The following is a description of a gene set: studied in species Homo sapiens Human Gene Set: HE_LIM_SUN_FETAL_LUNG_C4_T_ALPHA_BETA_ENTRY_CELL from publication He P, Lim K, Sun D, Pett JP, Jeng Q, Polanski K, Dong Z, Bolt L, Richardson L, Mamanova L, Dabrowska M, Wilbrey-Clark A, Madissoon E, Tuong ZK, Dann E, Suo C, Goh I, Yoshida M, Nikolić MZ, Janes SM, He X, Barker RA, Teichmann SA, Marioni JC, Meyer KB, Rawlins EL (PMID 36493756) Tαβ_Entry, and this is the list of marker genes: MOB1B, EPHB6, RRAGB, PIKFYVE, TSHR, BCL7A, BCOR, LETM1, PTCRA, AEBP1, APC, PCSK5, TBC1D19, KCNA3, PRKCG, ZNF518B, ARHGEF7, PITPNM2, SH3TC1, RAG2, CD2AP, THEMIS, MZB1, ETV6, PTK7, GNA15, DAPK1, PTPRM, GALNT7, SSBP2, RORC, CD1B, SCAI, LDLRAD4, CBFA2T3, MSI2, ELOVL4, MIR181A1HG, MED13L, FOXK2, TLE3, PELI2, EDEM1 (ER degradation enhancing alpha-mannosidase like protein 1), DNASE1, CD1A, PPP1R1C, MTRFR, ITPR2, MAP1A, CYP2U1, CD1C, RANBP6, RAG1, NREP, RASSF6, VOPP1, SLC29A1, RPTOR, ARPP21, CCR9, CD1E, ANKRD36, MAFK, CD8B, ADORA2A, MCTP1, TNFRSF21, CD4, TBL2, GSE1